Given this list of marker genes NDNF, SPRY4 (NCBI Gene Id 81848), TMEM147, MEOX1, NTN1, SVBP, GDF3, LARGE1, HESX1, KNL1 (kinetochore scaffold 1), HS6ST1, FGF8, CCDC141, CDH2, FGFR1, DNAL4, PROKR2 (NCBI Gene Id 3733), DUSP6, ANOS1, WDR11 (WD repeat domain 11), CEP152, IL17RD, DCC (DCC netrin 1 receptor), FGF17, RAD51, PROK2, GDF6 (NCBI Gene Id 9571), ROBO1, SOX10, CHD7, FLRT3, TACR3, SEMA3A, FEZF1, here is a description of the gene set: studied in species Homo sapiens Human Gene Set: HP_SYNKINESIS Synkinesis Unintentional movement in one area of the body produced during intentional movement of another area of the body.